Given this list of marker genes SENP1, SPOCK2, PABPN1L, CRB2, HSP90AB1 (NCBI Gene Id 3326), PLAU, MAGEA3, TLK2, PSMF1, SHH, CSNK2B, OPHN1, PHF20L1, ACP4, THBS1, UBXN1, PANO1, SUFU, MAP1A, PLAT, CST3, SIRT4, CSTB, ECM1, IDE, SERPINB13, PSME3IP1, KNG1, PDCL3, USP7, TIMP1, QRICH2, PARK7, SERPINE1, CDK5, PRNP, CSNK2A1, TM4SF20, TAF9, EFNA1, HDAC6, WNT1, MTM1, PBK, PRKCG, USP14, PML, STYX, SGTA, TTC36, AQP11, CDKN2A, RPS7, CAMLG, CCAR2, SPOCK3, TAF1 (TATA-box binding protein associated factor 1), SERPINB1 (NCBI Gene Id 1992), HFE, EIF3H, TIMP2, SERPINB9, AKT1, BAG6, USP5, NLRP7 (NLR family pyrin domain containing 7), FETUB, CLN3, GAS1, CLN8, F8A3, CTSZ, RPL5, USP9X, GABARAPL2, RYBP, TRIM39, GAPDH, GLG1, IL1R2, VTN, DDRGK1, LAMP3, SERPINF2, ALAD, MDM2, SVIP, KLHL40, LRRK2, MIR128-1, SPINK5, IL10, TIMP3, USP17L2, PSEN1 (NCBI Gene Id 5663), SNX12, CSNK2A2, GIPC1, UBXN2A, EPHA4, FHIT, PRMT6, WAC, TMEM98, MIR126, ARHGAP5-AS1, F2, RPL11, SMARCC1, N4BP1, USP26, LRIG2, BAG5, SERPINE2, F8A1 (coagulation factor VIII associated 1), MIR152, OGT, CSTA, PTPN3, MARCHF7, NR1H3, CHAC1, NR1H2, UFSP2, DNAJC1, EPPIN, CR1, CST4, ROCK1, FURIN, SERPINB8, HIPK2, USP38, UCHL5, RPL23, SERPINB4, F8A2, TP53, TIMP4, USP25, SERPINB3, NOP53, RECK, here is a description of the gene set: studied in species Homo sapiens Any process that stops, prevents, or reduces the frequency, rate or extent of the hydrolysis of a peptide bond or bonds within a protein. Human Gene Set: GOBP_NEGATIVE_REGULATION_OF_PROTEOLYSIS